Given this list of marker genes HPCAL1, IMPA2, BMAL2, HS3ST2, SLC43A1, RBMS2, FUCA1, CXCL2 (NCBI Gene Id 2920), GMEB1, ADD3, LEF1, KRT5, PMP22, here is a description of the gene set: from publication García-Piñeres AJ, Hildesheim A, Dodd L, Kemp TJ, Yang J, Fullmer B, Harro C, Lowy DR, Lempicki RA, Pinto LA (PMID 19155521) Genes negatively correlated with antibody response in peripheral blood mononuclear cell in young adults (18-25) after exposure to HPV-16 L1 VLP, time point 7M. Comment: Spearman Correlation of Gene Expression with Neutralizing Antibody Levels Human Gene Set: GARCIA_PINERES_PBMC_HPV_16_L1_VLP_AGE_18_25YO_7MO_CORRELATED_WITH_ANTIBODY_RESPONSE_NEGATIVE Human papillomavirus (HPV) virus-like particle (VLP) vaccines were recently licensed. Although neutralizing Ab titers are thought to be the main effectors of protection against infection, early predictors of long-term efficacy are not yet defined and a comprehensive understanding of innate and adaptive immune responses to vaccination is still lacking. Here, microarrays were used to compare the gene expression signature in HPV-16 L1 VLP-stimulated PBMCs from 17 vaccine and 4 placebo recipients before vaccination and 1 mo after receiving the second immunization. Vaccination with a monovalent HPV-16 L1 VLP vaccine was associated with modulation of genes involved in the inflammatory/defense response, cytokine, IFN, and cell cycle pathways in VLP-stimulated PBMCs. Additionally, there was up-regulation of probesets associated with cytotoxic (GZMB, TNFSF10) and regulatory (INDO, CTLA4) activities. The strongest correlations with neutralizing Ab titers were found for cyclin D2 (CCND2) and galectin (LGALS2). Twenty-two differentially expressed probesets were selected for confirmation by RT-PCR in an independent sample set. Agreement with microarray data was seen for more than two-thirds of these probesets. Up-regulation of immune/defense response genes by HPV-16 L1 VLP, in particular, IFN-induced genes, was observed in PBMCs collected before vaccination, with many of these genes being further induced following vaccination. In conclusion, we identified important innate and adaptive response-related genes induced by vaccination with HPV-16 L1 VLP. Further studies are needed to identify gene expression signatures of immunogenicity and long-term protection with potential utility in prediction of long-term HPV vaccination outcomes in clinical trials. studied in species Homo sapiens